The following is a description of a gene set: studied in species Homo sapiens Limb muscle weakness Human Gene Set: HP_LIMB_MUSCLE_WEAKNESS Reduced strength and weakness of the muscles of the arms and legs., and this is the list of marker genes: AMPD3, HACD1, NEB, COL13A1, LDB3, TTN (titin), POLG2, SIGMAR1, TK2, RTN2, FLNC, PDXK, RRM1, SPG7, SMARCB1 (NCBI Gene Id 6598), SMN1, MCM3AP, FKTN, ATL1, DUX4L1, SUFU, POPDC3, ADAR, PIGN, PNPLA6, MRPS2, GMPPB (NCBI Gene Id 29925), CYP7B1, SBF1, SYT2, SLC12A6, GBA2, MB, AGRN, ITPR1, SMCHD1, UBAP1, SECISBP2, TAF15, SPART, MTRFR (NCBI Gene Id 91574), SLC25A21, SH3TC2, GNB4 (G protein subunit beta 4), TRAF7, CCNF, CHMP2B, DSTYK, PPARGC1A, DOK7, COL6A2, WARS1, AP5Z1, SNAP25 (NCBI Gene Id 6616), ABCD1, TRIM32, MFN2, GIPC1, LIG3, DDHD1, LRSAM1, COA7, TARDBP, CCND1, DNAJB2, DYM, GAN, FHL1, PLP1, DGUOK, FGD4, TPM3, REEP1, SARDH, LAMA2, ADSS1, ERLIN2, PTRHD1, FBLN5, MTTP (microsomal triglyceride transfer protein), CYP27A1, PMP2, FDX2, TRPV4, YARS1, PDK3 (pyruvate dehydrogenase kinase 3), KIF1B, DMD, DYSF, COL6A3, RASA1, PPOX, COX6A1, PFN1, TFG (trafficking from ER to golgi regulator), CRPPA, LYST, GFAP, DDHD2, BVES, KIF1A, IBA57, ACTN2, RNF31, DNM2, UNC13A, SCN4A, FUS, CHRNE, SLC18A3, CACNA1S, SYNE1, DHTKD1, HNRNPA2B1 (NCBI Gene Id 3181), LAMP2, RNASEH1, GABRA3, TBK1, FLI1, SORD, FBXO38, HK1, COL6A1, PRX, LBR, MTAP, EMILIN1, SDHA, PON1, ERBB4, CRYAB, TYMP, MYL2, GYG1, HYCC1, HMBS, CPT1C, RFXAP, FRG1, COLQ, HNRNPA1, AKT1, PABPN1 (poly(A) binding protein nuclear 1), HADHB (hydroxyacyl-CoA dehydrogenase trifunctional multienzyme complex subunit beta), SMO, VAMP1, PNKP, SMN2, CAPN1, CHRND, KLHL41, FIG4, ANO5, SNUPN, KY, AARS1 (NCBI Gene Id 16), SPTAN1, BICD2, ALAD (NCBI Gene Id 210), SACS, MPZ, TBCK, SGCG, MT-ATP6, PDGFB, INF2, RNF170, AK9, SPTLC1, RETREG1, KARS1, MLIP, CFL2, POGLUT1, MPV17, MYH7, TDP1, ANXA11, HSPB3, SOD1, SCYL2, BSCL2, CAPN3, MATR3, SQSTM1, POLG, GLE1, SCYL1, HSPB8, SLC33A1, SYNE2, PMP22, VWA1, LMOD3, PLEC, POMT1, WASHC5, PEX7, PON3, HSPG2, PLIN4, EXTL3, PI4KA, MYH14, PRPH, EIF2B3, DAO, SMARCE1, MT-CO1, RAPSN, L1CAM, ATL3 (NCBI Gene Id 283241), KCNJ18, RAI1, PYROXD1, MAPT, RILPL1, HINT1, PLOD1, DUX4 (double homeobox 4), AMPD1, TREM2, TRIP4, HSPD1, SLC5A7 (NCBI Gene Id 60482), ALDH18A1, MYOT, ATP5MC3, ASAH1, OBSCN, SPG21, VPS13A, CPOX, NOTCH2NLC, VHL, MME, NEFL, KCNJ10 (NCBI Gene Id 3766), AFG3L2, ATP7B, SPG11, CHCHD10, CHRNA1, PON2, NUP62, FA2H, BAG3, VAPB, GLT8D1 (NCBI Gene Id 91870), SLC5A6, ORAI1, HARS1, FARS2, TCAP, COL25A1, RAB7A, ATXN2, KBTBD13, SEPTIN9, VCP, UBQLN2, SPTLC2, NEK1, BAP1 (BRCA1 associated deubiquitinase 1), SMPX, ANG, MAP3K20, PNPLA2, HEXB, LRP12, ZFYVE26, KPNA3 (karyopherin subunit alpha 3), TIA1, HSPB1, CD59, JAG2, TWNK, MORC2 (MORC family CW-type zinc finger 2), CADM3, B4GALNT1, ACOX1, IGHMBP2, GJB1, POU3F4, GBF1, ITGA7, DYNC1H1, LRP4, PIK3CA, TNNT1, GALC, SLC25A1 (NCBI Gene Id 6576), TMEM43, NF2, PRORP, SCO2, PHYH, MYO9A, TBCE, BIN1, NUP54, COL12A1 (collagen type XII alpha 1 chain), HADHA, TPM2, SBF2, SELENON, ACTA1, COX20, GNB1, GDAP1, PRNP, MYPN, CHAT, GARS1, NF1, OPTN, MTMR14, GNB2, EGR2, DMXL2, EMD, CFAP410, BTD, NEFH, RRM2B, FMR1, KIF5A, MTHFR, SPAST, LPIN1, GNE, PHKA1, AR (androgen receptor), VPS13D, COQ7, CAV1, LIPE, SLC52A2, RYR1, LMNA, TERT, DNMT3B (NCBI Gene Id 1789), CHRNB1, HMGCR, EIF2B2, DCTN1, DES, NIPA1, SLC25A4, PIEZO2, AIFM1, MEGF10, ERGIC1, MT-CO3, MARS1, JAG1, NDRG1, ATP1A1, GAA, VMA21, MUSK, MYF6